The following is a description of a gene set: The chemical reactions and pathways involving phosphatidylethanolamine, any of a class of glycerophospholipids in which a phosphatidyl group is esterified to the hydroxyl group of ethanolamine. It is a major structural phospholipid in mammalian systems. It tends to be more abundant than phosphatidylcholine in the internal membranes of the cell and is an abundant component of prokaryotic membranes. species: Homo sapiens Human Gene Set: GOBP_PHOSPHATIDYLETHANOLAMINE_METABOLIC_PROCESS, and this is the list of marker genes: PLA2G2D, ETNK2, PLA2G6, NAAA, SELENOI, PLAAT1, PNPLA8, PCYT2 (NCBI Gene Id 5833), NAPEPLD, PLAAT5, LPIN1, PLAAT2, PLA2G15, CHKB, PLAAT4, PLA2G4E, PLB1, PLA2G10, CEPT1, PLA2G3, ABHD4, PLA2G2A, PLAAT3, MFSD2A, PISD, CHKA (NCBI Gene Id 1119), ETNK1, ALOX15